The following is a description of a gene set: from publication Suryani S, Fulcher DA, Santner-Nanan B, Nanan R, Wong M, Shaw PJ, Gibson J, Williams A, Tangye SG (PMID 19965666) Human Gene Set: GSE17186_BLOOD_VS_CORD_BLOOD_CD21LOW_TRANSITIONAL_BCELL_DN Goals/objectives: to identify various gene expression in B cell subsets derived from human PBMC and cord blood Genes down-regulated in transitional CR2 low B lymphocytes versus those from cord blood. species: Homo sapiens, and this is the list of marker genes: FSIP1, HPS5, IDH1, MT1E, CORO2A, KDM3B, PTPRE, ADAM9, TMEM131, PLEKHO2, INPPL1, MGAT4B, GOLGA7, MAPK13, CASP7, MYO18A, EXTL3, NADK, NDST2, TPCN2, GNA15, POGLUT3, CD302, ACVR2A, SPINT1, SLC12A9, HEG1, SLC25A10, TTC8, KCTD14, ACSF3, PLS3, FNDC5, SORD, TIAM1, RAB14, APIP, BCL9, ACVRL1 (activin A receptor like type 1), WDFY3, ATP7A, RPS6KA5, SDC3, RALB, TUSC1, USP22, TNFRSF21, PLSCR1, YWHAG, ZC3H12D, BBS5, SLC8A1, CCNYL1, SLC35B2, NAALAD2, LONRF1, KCNK12, TPM2, CDON, SEL1L, PPFIA4, MAP2K3, WDR86, CFAP410 (NCBI Gene Id 755, cilia and flagella associated protein 410), HSP90B1, SLC33A1, KIF9, ARHGAP5, EZH2, CRYBG3 (NCBI Gene Id 131544), PMF1, E2F3, RAB11FIP1, PDE8A, GYS1, POGLUT2, ARHGAP6, FARP2 (NCBI Gene Id 9855), BIRC5, TAF6L (TATA-box binding protein associated factor 6 like), MIER2, NUDT15, DPAGT1, PUS10, HIPK2, ABRAXAS2, ABL1, ARMC8, EEA1 (early endosome antigen 1), FNDC3A, CSF2RB, SNX9, MBD4, H2BC5, LSR, RNF141, GALNT7, SREBF2, NUDT2, USP6NL, C1orf21, SLC25A26, ITM2C, ELMO2, ENDOD1, SLC31A2, SLC6A13, CLNK (NCBI Gene Id 116449), HPS4, VKORC1L1, NAIF1, LPCAT1, SRGAP2, FBXO3, ZNF710, FAM174A, TTC7A, DYNLT2B, PHF10, TXNDC16, PRKAB2, ARL8A, ERCC6L, ANXA2 (annexin A2), CAMK1, ALMS1, SPAG9, RTL5, METRNL, SH3BGRL, CD80, TMBIM1, UBE2G2, ITGAV, PRRC1, PLBD2, FADD, UNC119B, SLC25A24, ZFYVE21, TYK2 (tyrosine kinase 2), ROPN1L, OSBPL3, CENPV, NCKIPSD, ACOX3, SERPINB1, CD180, TPST1, GCNT1, RHOQ, NRP1, MAPKAPK2, HDAC9, HELLS, VAMP3, ADSS1, TYW3, EFCAB14, PCLAF, APP, GNG10, IFITM2, DEPDC7, SNX22, LPIN2, ASAP2, CCNE2, FBXO6, RAB10, MFSD14A, EXOC3L4, PKIG, HLA-G, SH3TC1, ARHGDIA, FCGRT, VPS37C, DYNC1LI2, DCTPP1, CDC14A, CHML, LIPA, CREB3L2, AKT1, CD99L2, TMEM170B, CARD10, H1-0, CDCA8, MKI67, MPRIP, RPN1, AMZ1, SLC66A3, ARAP1, FAM91A1, TNFAIP2, SIPA1L3, KDM2B